Given this list of marker genes ZNF107, PTGFRN, INO80D, CLCN4, SETD7, RORA, CCNT1, MTOR, NUDT19, ZNF333, BRWD3, PAPPA, SPAG11B, ZMAT2, ZNF765 (NCBI Gene Id 91661), ZNF780B, ZNF780A, ZNF781, CHST6, BIRC6, SLC7A8, EBF1, BRI3, MAFB, TANC1, NUMB, CEACAM6, ZNF594, RHBDL3, ZNF135, ZNF426, CDYL, KIF2A, PIK3R4, ZNF684, ZNF493, JADE1, GABRA5, ZNF74, MRPL30, DRD1, TERF2, ZNF195, ZNF189, FBXO9, SPATA33, MAGEB18, ZNF573, RAP2C, TMEM215, FKBP5, POGLUT1, ZNF14, PKIB (cAMP-dependent protein kinase inhibitor beta), KHDC1, ZCCHC24, ZNF430, RFFL, CACNA1E, KLF4, CISD2, CCNG2, WDR89, FBXL5, EPG5, PIM2, GABRG2, RBPMS2, PPM1A, EIF4G2, AFF2, SNCA, ZNF568 (NCBI Gene Id 654171), CADM1, TSEN2, LGALSL, ZNF559-ZNF177, TLCD5, RIMKLA, KHDC1L, MARCHF3, ZDBF2, ILDR2, TBX18, here is a description of the gene set: Genes predicted to be targets of miRBase v22 microRNA hsa-miR-1229-3p in miRDB v6.0 with MirTarget v4 prediction scores > 80 (high confidence targets). from publication Chen Y, Wang X (PMID 31504780) studied in species Homo sapiens Human Gene Set: MIR1229_3P